The following is a description of a gene set: from publication Min L, Isa SA, Fam WN, Sze SK, Beretta O, Mortellaro A, Ruedl C (PMID 22250091) species: Homo sapiens A simultaneous engagement of different pathogen recognition receptors provides a tailor made adaptive immunity for an efficient defence against distinct pathogens. For example, cross talk of TLR and c-type lectin signalling effectively shapes distinct gene expression patterns by integrating the signals at the level of NF-κB. Here, we extend this principle to a strong synergism between the Dectin-1 agonist, curdlan, and an inflammatory growth factor, GM-CSF. Both together act in synergy in inducing a strong inflammatory signature which converts immature DCs to potent effector DCs. A variety of cytokines (IL-1β, IL-6, TNF-α, IL-2 and IL-12p70), costimulatory molecules (CD80, CD86, CD40 and CD70), chemokines (CxCl1, CxCl2, CxCl3, CCl12, CCl17) as well as receptors and molecules involved in fugal recognition and immunity such as Mincle, Dectin-1, Dectin-2 and Pentraxin 3 are strongly up-regulated in DC treated simultaneously with curdlan and GM-CSF. The synergistic effect of both stimuli resulted in strong IKBα phosphorylation, in its rapid degradation and in enhanced nuclear translocation of all NF-κB subunits. We further identified MAPK ERK, as one possible integration site of both signals, since its phosphorylation was clearly augmented when curdlan was co-applied with GM-CSF. Our data demonstrate that the immunomodulatory activity of curdlan requires an additional signal provided by GM-CSF to successfully initiate a robust β-glucan specific cytokine and chemokine response. The integration of both signals clearly prime and tailor a more effective innate and adaptive response against invading microbes and fungi. Human Gene Set: GSE32986_CURDLAN_HIGHDOSE_VS_GMCSF_AND_CURDLAN_HIGHDOSE_STIM_DC_UP Genes up-regulated in bone marrow-derived dendritic cells: high dose of 1,3-beta-D-oligoglucan versus CSF2 and high dose of 1,3-beta-D-oligoglucan., and this is the list of marker genes: HSD3B7, NAGK, DNAJC12 (DnaJ heat shock protein family (Hsp40) member C12), SYNJ1, CERT1, DHX40, SIL1, RNASEL, BAZ2B, VPS11, SLC66A3, TSPAN3, GABARAPL1 (GABA type A receptor associated protein like 1), PDP1, NEURL1B, ZFYVE1, MED23, CYFIP2, STAG2, VAMP2, MXD1, PDPR, RMND1, RAD50, PMP22, ZBTB11-AS1, RCHY1, RRAGC, SYNPO2, PDK2, RPA1, RAPGEF3, SURF1, C19orf47, PDLIM4, FTO, TAX1BP1, NAT9, ABTB1, IFIT3, HFE, TRIM6, USP21, SMPDL3A, BLOC1S1, PSEN1, TMEM126B, FBLIM1, PURG, LRRC61, NT5M (5',3'-nucleotidase, mitochondrial), TBC1D31, DYNLT1, KIF5A, FGFBP3, ATP6V1C1, LAMTOR4 (NCBI Gene Id 392758), CCNG2, ABCD3, ILK, FAM32A (family with sequence similarity 32 member A), SQOR, CHKB, RASSF3, INPP1, RFWD3, GLT8D1, TST, BUB1, SLC7A7, RAB32, OMA1, NHSL3, SPRY2, SERPINB6, DNAH2, PPM1H, ATP8B4, CD68, ABHD4, APOBEC1, TMEM18 (transmembrane protein 18, NCBI Gene Id 129787), SSH3, MSL3, ZNF467, TBC1D9, ARMC2, TMEM38B, FUOM, OGA, LPXN, FBXL8, MSRB2, RELCH, OIT3, CHPT1, ZRANB3, ANAPC7, CDKN1B, ING1, GET3, DIP2A, ABCC4, PTPRA, GLG1, LRMDA, LIX1L, WBP1L, DNMT1 (NCBI Gene Id 1786), KLF3, CNPY4, SEMA4D, IL16, RAPH1 (NCBI Gene Id 80729), CPT1A, TCIRG1, CAMK1, C1orf54, STARD8, PRIMPOL, PHF21A, SUSD1, STAT4, FECH, HEXB, PLEKHM3, LPIN2, SERPINE2, DTNBP1, RIT1 (NCBI Gene Id 6016), PARP11, MFAP3L, MAVS, MAP3K9, RNASE4, SMPD1, GSTO1, RCBTB2, TLR4, METRNL, NCOA2, HMG20A, GOLGA2, PLPP6, ARHGAP9, COLEC12, SYNGR1, TOM1 (target of myb1 membrane trafficking protein), FBXO8, CDKAL1, SLC35F5, TPGS1, SORL1, POLD3, PHKA2, AIFM2 (AIF family member 2), PLXNB2, SENP8 (NCBI Gene Id 123228), UBL3, TNKS, SEL1L3, HCFC1R1, E2F7, DCAF6, NMRK1, INCENP, MINDY2, OPHN1, FKBPL, INTS6L, STOM, OARD1, NAT1, AKAP11, TIFA, ZFYVE26, CGGBP1, LIN37, RETREG2, RNPEP, BLVRA, SLFN5, NPRL2, GRB2, WLS, SMC2, GABPB2, CRYL1, WDR62, RBL1, HPGDS, RASSF8, TMT1A, UBE2R2, CACFD1, GALNT4, PLCL2, TANC2 (NCBI Gene Id 80259), TET1